The following is a description of a gene set: Fatigable weakness of distal limb muscles species: Homo sapiens Human Gene Set: HP_FATIGABLE_WEAKNESS_OF_DISTAL_LIMB_MUSCLES A type of weakness of a skeletal muscle of distal part of a limb that occurs after a muscle group is used and lessens if the muscle group has some rest. That is, there is diminution of strength with repetitive muscle actions., and this is the list of marker genes: LDB3, HINT1, NEB, KLHL41, CFL2, TPM2, ACTA1, LMOD3